Given this list of marker genes LYN, MEFV, DNASE1L3, WAS (WASP actin nucleation promoting factor), PTPN6, here is a description of the gene set: studied in species Homo sapiens Human Gene Set: HP_SMALL_VESSEL_VASCULITIS A type of vasculitis (inflammation of blood vessel walls) that affects blood vessels that are smaller than arteries, i.e., arterioles, venules, and capilllaries. Small vessel vasculitis